Given this list of marker genes FOXO4, RBL2, KLF4, SMAD3, CDKN1B, BTG1, PCBP4, CDKN1A, FOXO3, FOXO1, SMAD4, SMAD2, CAV1, CCNG2, FOXG1, MSTN, GADD45A, here is a description of the gene set: FOXO-mediated transcription of cell cycle genes Human Gene Set: REACTOME_FOXO_MEDIATED_TRANSCRIPTION_OF_CELL_CYCLE_GENES studied in species Homo sapiens